Given this list of marker genes ATXN2L, ZC3H12A, OCSTAMP, PIM3, MRPL54, NFKBID, GK5, FOSL1, TTF1, CITED2, CUL4A, PURB, WEE1, PDE4B, FUBP3, PPP1R15A, IL10RA, RLIM, HIPK2, MAFF, LCORL, CCL4, TNFAIP3, NFKBIA, PALS2, CHP1, TNF, LTA, HADHB, PTGS2, SOWAHC, SRF, DUSP1, PHLDA1 (pleckstrin homology like domain family A member 1), MEFV, MARCKSL1, HNRNPD, C6orf89, BASP1, RRAD, GADD45A, CCDC186, DUSP5, ERRFI1, YTHDC1, FAM83D, SNX16, TMEM88, ZNF560, PLEK, MIXL1, CRACDL, DNAJB4, CHUK, RASGEF1B, RYBP, FANCL, SOCS3, SERTAD1, ISG20L2, DUSP2, RASEF, PDE6D, ZNF317, IER5, FILIP1L, TAGAP, MCL1, WAPL, AREG, PHF1, MAP10, LAPTM5, SLC35A2, ENPP4, LTB, GSR, MAP3K8, NFKBIZ, CXCL10, DOT1L, ARG2, LINC01160, CDV3, SMIM14, ERGIC1, DDX5, GAB2, SPACA1, IGFBP2, YWHAG, TRIB1, IDI1, PAXBP1, MDM2, SRGN, PPP2R2A, PRDM1, BACH1, SLC35D1, NINJ1, APOO, KMT2D, TNFAIP2, CMTM6, DHX15, RSBN1, BCL10, ETS2, NAT14, LRP4, EGR1, CXCR4 (NCBI Gene Id 93405), EPHA2, ODC1, TNFRSF1B, ZNF131, PTGER4, IRS2, SYCP3, RFX3, IL1B, ACOD1, MRPL32, CCL5, FOXN2, DYNC1I1, VPS37C, CCDC88B, PCDH17, SHQ1, NR4A3, CSRNP1, CDKN1A, ICAM1, CDK5R1, GCNT1, HNRNPK, LAMP2, RAB20, CCRL2, CLCF1, RNPC3, ANXA11, JDP2 (NCBI Gene Id 122953), ZFP36, GEM, PLD3, IL6, SLC15A3, EEF1AKMT2, ARMT1, KDM6B, C9orf72, GPSM1, ITPKC, TESK2, FBLN7, NFKBIB (NCBI Gene Id 4793), RPS16, UXT, C19orf18, CXCL3, CHCHD2, ADM, LIF, ETV3, ZFP36L1, JUN (Jun proto-oncogene, AP-1 transcription factor subunit), MPHOSPH9, TAMALIN, IL31, BCL2A1, RGS1, BLOC1S3, TRIM35, CXCL16, RAB11A, AMPD3, NUDT9, PPIF, LRRC57, TRAF1, SMC5, LACC1, IER3, ACSS2, ARMCX4, CACNA1S, IL12B, ADORA2B, SERPINB2, NRROS, EHBP1L1, AIPL1, STK40, EHD1, CKLF, TGIF1, IFRD1, here is a description of the gene set: from publication Ochiai K, Maienschein-Cline M, Simonetti G, Chen J, Rosenthal R, Brink R, Chong AS, Klein U, Dinner AR, Singh H, Sciammas R (PMID 23684984) Human Gene Set: GSE46606_UNSTIM_VS_CD40L_IL2_IL5_1DAY_STIMULATED_IRF4HIGH_SORTED_BCELL_DN Temporal analysis of B cell activation in vitro using CD40L and IL-2/4/5 cytokines in wild type Irf4+/+ B cells or in mutant Irf4-/- B cells harboring a tet-inducible allele of Irf4. IRF4 expression was restored, or not, in the Irf4-/- background by culturing in the presence of low or high concentrations of doxycycline. The results provide insight in the role of IRF4 expression levels in coordinating different programs of B cell differentiation. species: Homo sapiens Genes down-regulated in at day 0 B cell IRF4-KO versus CD40L and IL-2 IL-4 IL-5 stimulated at day 1 B cell IRF4high.